Given this list of marker genes Tgfb3, Mylk3, Il1b, Abcc8, Tgfbr1, here is a description of the gene set: Any process that modulates the frequency, rate or extent of tight junction disassembly. species: Mus musculus Mouse Gene Set: GOBP_REGULATION_OF_TIGHT_JUNCTION_DISASSEMBLY